The following is a description of a gene set: Human Gene Set: HP_UNILATERAL_CLEFT_PALATE Unilateral cleft palate studied in species Homo sapiens, and this is the list of marker genes: CDH1, COBLL1, CDH11, GDF11, RIC1, DLX4, MED12, MSX1, BMP4, DLG1, PTCH1, TP63, SUMO1, ARHGEF38, ARHGAP29, PDGFRA, NECTIN1, KAT5, IRF6, ASXL1